Given this list of marker genes 1700025G04Rik, Gja3, Scrt2, Tnn, Aplnr, Ptgdr2, Ifnar2 (interferon (alpha and beta) receptor 2), Zcchc3, Nrn1, here is a description of the gene set: Mouse Gene Set: MIR_7034_5P species: Mus musculus from publication Chen Y, Wang X (PMID 31504780) Genes predicted to be targets of miRBase v22 microRNA mmu_miR_7034_5p in miRDB v6.0 with MirTarget v4 prediction scores > 80 (high confidence targets).